The following is a description of a gene set: Mouse Gene Set: GOBP_SEROTONERGIC_NEURON_AXON_GUIDANCE species: Mus musculus The chemotaxis process that directs the migration of an axon growth cone of a serotonergic neuron to a specific target site in response to a combination of attractive and repulsive cues., and this is the list of marker genes: Celsr3, Pcdhac2, Wnt5a, Vangl2, Fzd3